Given this list of marker genes Mesp1, Isl1, Bves, Tbx3, Popdc2, Shox2, Tbx18, here is a description of the gene set: species: Mus musculus The process in which a relatively unspecialized cell acquires specialized features of a sinoatrial (SA) node cell. SA node cells are pacemaker cells that are found in the sinoatrial node. Mouse Gene Set: GOBP_SINOATRIAL_NODE_CELL_DIFFERENTIATION